Given this list of marker genes Ubc, Map2k4, Mapk3, Mapk1 (mitogen-activated protein kinase 1), Jun, Kdm6b, Rps27a, Mapkapk2, Cdk4, Txn1, Tnik, Trp53, Map3k5, Map2k6, Mdm2, Mapk14, Map2k3, Uba52rt, Rbbp7 (retinoblastoma binding protein 7, chromatin remodeling factor), Ubb, Rbbp4, Mapkapk3, Mapk11, Uba52, Fos (NCBI Gene Id 14281), Map2k7, Cdk6, Mink1, Map4k4, Cdkn2b, Ezh2, Eed, Mapk10, Suz12, Mapkapk5, Mapk8, Mdm4, Mapk9, here is a description of the gene set: Oxidative Stress Induced Senescence Mouse Gene Set: REACTOME_OXIDATIVE_STRESS_INDUCED_SENESCENCE studied in species Mus musculus